Given this list of marker genes FCN1, COLEC10, MASP2, FCN3, F2, MBL2 (NCBI Gene Id 4153), FCN2, COLEC11, here is a description of the gene set: Pathway Definition from KEGG: F2 -- ((MBL2,COLEC10/11,FCN)+MASP2) -> F2a Human Gene Set: KEGG_MEDICUS_REFERENCE_LECTIN_PATHWAY_OF_COAGULATION_CASCADE_PROTHROMBIN_TO_THROMBIN Lectin pathway of coagulation cascade, prothrombin to thrombin. Pathway ID: N01315. Pathway type: Reference. Pathway class: nt06171 SARS coronavirus 2 (SARS-CoV-2). species: Homo sapiens